Given this list of marker genes CRYGS, ACADS, SEC23A, CRYBA1, GJA8, NHS, CRYBB2, GJA5, here is a description of the gene set: A type of congenital cataract in which the opacity follows the anterior or posterior Y suture. studied in species Homo sapiens Sutural cataract Human Gene Set: HP_SUTURAL_CATARACT